The following is a description of a gene set: Interm fibro from publication He P, Lim K, Sun D, Pett JP, Jeng Q, Polanski K, Dong Z, Bolt L, Richardson L, Mamanova L, Dabrowska M, Wilbrey-Clark A, Madissoon E, Tuong ZK, Dann E, Suo C, Goh I, Yoshida M, Nikolić MZ, Janes SM, He X, Barker RA, Teichmann SA, Marioni JC, Meyer KB, Rawlins EL (PMID 36493756) Human Gene Set: HE_LIM_SUN_FETAL_LUNG_C0_INTERM_FIBROBLAST species: Homo sapiens, and this is the list of marker genes: CFD, FMO1, CNTN1, ALDH1A1, CNTNAP2, CA3, ANXA1, PAMR1, GGT5